The following is a description of a gene set: Comprehensive identification of all functional elements encoded in the human genome is a fundamental need in biomedical research. Here, we present a comparative analysis of the human, mouse, rat and dog genomes to create a systematic catalogue of common regulatory motifs in promoters and 3' untranslated regions (3' UTRs). The promoter analysis yields 174 candidate motifs, including most previously known transcription-factor binding sites and 105 new motifs. The 3'-UTR analysis yields 106 motifs likely to be involved in post-transcriptional regulation. Nearly one-half are associated with microRNAs (miRNAs), leading to the discovery of many new miRNA genes and their likely target genes. Our results suggest that previous estimates of the number of human miRNA genes were low, and that miRNAs regulate at least 20% of human genes. The overall results provide a systematic view of gene regulation in the human, which will be refined as additional mammalian genomes become available. Genes having at least one occurrence of the highly conserved motif M131 GATAAGR in the regions spanning 4 kb centered on their transcription starting sites. This matches the transcription factor binding site V$GATA_C (v7.4 TRANSFAC). species: Homo sapiens from publication Xie X, Lu J, Kulbokas EJ, Golub TR, Mootha V, Lindblad-Toh K, Lander ES, Kellis M (PMID 15735639) Human Gene Set: GATAAGR_GATA_C, and this is the list of marker genes: MYRF, APOOL, GRHL2, SLC34A3, ANKS1B, SLC2A7, HOXB4, RHAG, PAX2, ENO2, NANOS1, TSPAN32, NRXN3, FLI1, EPX, GATM, FHL3, SPINK4, TRIM10, ROBO1, LHX6, HOXD10, PLA2G1B, GATA1, SYT7, OR8B8, NRP2, MYH7, MECOM, EN1, TNFRSF19, PTPRR, ISL1, LEMD1, PPARGC1A, SLC46A1, KCNH5, ADD3, KRT15, RSPO2, CCSER2, IRS1, LUC7L3, CD34, MEF2C, TNK2, NHERF1, MCU, PCDH11Y, ETV1 (ETS variant transcription factor 1), TRPS1, PITX2, RBPMS, PPOX, KCNJ13, NFE2, IL22, NTF3, TRIM15, PRSS1, PHOSPHO1, ALDOA, TM4SF5, PSD4, FMO4, CAPN1, SOAT1 (NCBI Gene Id 6646), BMP6, RNF123, TSC22D3, BIN1, CLDN7, AQP2, CHRNB1, CA4, PCDHB8, GRB7, USH1G, LYL1, MTMR10 (myotubularin related protein 10), RPL13A, LINC00656, SLC7A8, PLAC1, TBX5, OTC, ZG16, CLRN3, SATB1, SGIP1, PRR34, HMGCS1, LMO2, CPOX, DSPP, ZFP36L1, PTPRC, BPGM (bisphosphoglycerate mutase), SLC7A7, SCUBE3, ANGPT2, DMTN, ZHX3, PKHD1L1, CHST4, TUBB2B, PPP2R3A, TSPAN12, GADD45G, EPB42, KLF1 (NCBI Gene Id 8055), PKIA, SH2B3, TMX4, NR2F1, REG4, LIX1, TDRD5, RNF144B, BSPRY, SALL1, RHCE, HOXC4, MTA2, NAA38, NPL, YPEL4, TSHB (thyroid stimulating hormone subunit beta), CHCHD7, KRT72, SLC26A9, ONECUT2, LMTK2 (NCBI Gene Id 22853), AK9, FERMT3 (FERM domain containing kindlin 3), CDK14, CCL27, KDM3A, HPSE2, ADPRHL1, FIGN, MYL7, XPO6, RHD, ARHGDIB, PDZD2, S1PR2, FEV, EDN1, MID1, FCGBP, FHL2, INHA, ZNF385B, CTNNA3, MITF, ECHDC2, IL4, CUX1, EGR2, PLAG1, MYH10, GABBR1, PRG2, FABP2, TFR2, PCF11, GSE1, NECTIN2, OTOP2, KRT80 (NCBI Gene Id 144501), MYT1, SPRY4, LCN15, GUCA2A, ERG, PPP1R17, NAA80, CREB5, NEBL, KRT23, HEPH, TMEM88, TNXB, MASP1, SLC6A14, ABCF3 (ATP binding cassette subfamily F member 3), RIMS1, FGF7, CACNA2D3, TCF21, CS, TOB1, EPG5, NR5A2, SOHLH2, DUSP2, IGFBP5 (NCBI Gene Id 3488), SIX1, AIF1L, EYA1, DMD, PKLR, SPAG9, PNLIPRP1, BTRC, SLC2A1 (NCBI Gene Id 6513), SOX5, ADAMTS3, RUNX1T1, NFIL3, ARF6, PRR18, ITPR1 (NCBI Gene Id 619543), PPT2, GRK6, NTF4, TAFA1, PTCHD4, ZFPM1, RPS27, MYO1C, PNLIPRP2, DYRK1A, MYH6, SLC26A7, PFKFB1, RAP1B, STON2, MSX2, MYO18A, ADCYAP1, GFRA3, WDR82, JUN, SLC4A1, MEIS2, SENP8, PLEKHG6, NLK, MLLT3, CYB5R3, CYB5D1, HMBS, UBE2F, FLRT3, MATN1, GIP, NCDN, SETD2, SPATA31H1, CSF2, KHK, HIC1, TRPM3, MOGAT2, PLN, ISYNA1, HYAL3, ASIC2, CDC42EP3, FZD4, HNF1A, SUSD1, MYCT1, AMHR2, NFATC3, HS3ST5, TACC1, BMP10, NFIA, MST1, CALHM5, LCAT, CTSE, CTNND1, ANKRD44, PTGDR2, GNB3, PRSS3, ELAVL4, FMO1 (NCBI Gene Id 2326), KDM5C, GPR155, STC1, CCDC80, NFIB, SDE2, SOX10, TAB2, B3GALT2, PPM1E, ABCA12, KRT20, SNW1, ST13P4, SPTSSB, ELF1, FAM91A1